Given this list of marker genes FOLH1B, AGTPBP1, AGBL4, AGBL5, FOLH1, AGBL1, here is a description of the gene set: The removal of a C-terminal, gene-encoded glutamate residue from a protein. studied in species Homo sapiens Human Gene Set: GOBP_C_TERMINAL_PROTEIN_DEGLUTAMYLATION